The following is a description of a gene set: Human Gene Set: GOBP_TELOMERE_CAPPING A process in which telomeres are protected from degradation and fusion, thereby ensuring chromosome stability by protecting the ends from both degradation and from being recognized as damaged DNA. May be mediated by specific single- or double-stranded telomeric DNA binding proteins. species: Homo sapiens, and this is the list of marker genes: POT1, TERF2, ATM, STN1, TNKS2, USP7, TINF2, SMG6, HNRNPD, TNKS, RTEL1, TFIP11, DCLRE1B, XRCC1, SPDYA, CTC1, PRKDC, TERF1, NABP2 (nucleic acid binding protein 2), RAD50, MRE11, ERCC1, ACD, TERF2IP, ERCC4, NBN, TEN1